Given this list of marker genes SH2B3, SRSF2, ASXL1, ABL1, PDGFRA (platelet derived growth factor receptor alpha), JAK2, ALAD, CALR, RUNX1, MPL, GATA2, GATA1, KIT, TET2, BCR, here is a description of the gene set: Human Gene Set: HP_MYELOPROLIFERATIVE_DISORDER species: Homo sapiens Proliferation (excess production) of hemopoietically active tissue or of tissue which has embryonic hemopoietic potential. Myeloproliferative disorder